The following is a description of a gene set: species: Homo sapiens Human Gene Set: GOBP_CEREBELLAR_GRANULAR_LAYER_DEVELOPMENT The process whose specific outcome is the progression of the cerebellar granule layer over time, from its formation to the mature structure. The granular layer is the innermost layer of the cerebellar cortex. This layer contains densely packed small neurons, mostly granule cells. Some Golgi cells are found at the outer border. Granule neurons send parallel fibers to the upper molecular layer, where they synapse with Purkinje cell dendrites. Mossy fibers from the pontine nuclei in the white matter synapse with granule cell axons, Golgi cell axons and unipolar brush interneuron axons at cerebellar glomeruli in the granule cell layer., and this is the list of marker genes: FAIM2, CEND1, KIF14, PROX1, MDK, NRXN1, OPHN1, KNDC1, GRID2, CBLN1, WNT7A, SERPINE2, TTBK2 (NCBI Gene Id 26044)